Given this list of marker genes ADGRB2, YY1AP1, SKA2, CENPN, MSRB3-AS1, TCTN1, WRAP53, SLC27A1, ZNF57, NDUFS3, BCCIP, FRAT1, UNKL, MTCP1, APOL4, ZC3H7A, BMS1P1, ENSG00000246792, PRELID3BP5, CUL7, SCARB1, PRTFDC1, GLUD1P2, TIGD6, ZNF271P, PODXL (NCBI Gene Id 5420), MAP3K7, MTERF3, PRKAR2A-AS1, FAM131B-AS2, RGCC, MTHFR, RBMXL1, SEPTIN9, TRIM33, LINC01124, VPS37C, KIAA1958, TIMM22 (NCBI Gene Id 95988), KLK8, HCG14, RPS17, NEBL-AS1, SIN3B, KCNAB2, BMS1, QPCTL, MAPKAPK3 (NCBI Gene Id 7867), MROH8, LYST, ATXN2, TOLLIP, TMEM102, C17orf58, CPLX1, WDR82, RNF24, GNAS, DDX56, OS9, SYBU-AS1, TARDBP, MED15, AHI1, KLF6, CMC2, KNL1, DDX5, BCAR3, FAM162A, NUBP2, WDR5-DT, H4C2, ULBP2, H4C12, WDFY3-AS2, MYL12B, TRAPPC9, ZHX1-C8orf76, SUN2, RUNX1T1, MPC1-DT (NCBI Gene Id 119545625), ZNF7, RITA1, PPP1R13L, LINC00896, PSMC3, DPP9, FNTA, NUP58, EHBP1, KYAT3, ASH1L, TMEM191A, SLC17A7, UGT8, FBXO8, CSPP1 (NCBI Gene Id 79848), IER5L-AS1, EVI5, CYP27B1, JMJD1C, RAD51AP1, PAXIP1-DT, HMGB2P1, CCDC157, HES1, SPATS2, SEMA6A, ZCCHC24, AP1G1, ATP8A1-DT, ATG10, MEN1, NFIX, HSDL2-AS1, TCAM1P, PKN1, NRSN2-AS1, LINC01664, CPSF2, EXD1, RPN2, FGF13, ALOXE3, GLUD1P3, NIP7, GTPBP3, TESC-AS1, ZNF300, STARD4, IER3-AS1, PLEKHM3, TMEM64, C2CD2L, ZNF213-AS1, FBXO33, SMIM36, NUP43, PAXIP1, CBX3P4, NOCT, ARHGAP9, FKBP4, CEP44, RPS27A, RIMBP3, COMMD5, FAM193B, COG8, ARL4A, AGRN, CIC, RNF43, MSLNL, NRSN2 (NCBI Gene Id 80023), PNPO, TSEN34, GDF15, MAOA, TMEM191B, ZNRF2, SNX12, SNRPD2, ALAD, MAP1LC3B, MBL1P, HSPE1-MOB4, TMEM260 (NCBI Gene Id 54916), PVALEF, NOX5, RPUSD1 (NCBI Gene Id 64723), MTG2, PDCD10, ATAD2, DVL3, SSX2IP, HNRNPUL1, VTRNA1-2, NT5DC2, CLHC1, ERP29, SPINDOC, ARL1, FOXA1, ANKRD27, PDK3 (NCBI Gene Id 5165), CCDC187, KBTBD8, FLOT1, MED16, BHLHE40, GSK3B, TBC1D5, LINC01287, MED13, ABHD14B, PKIA (cAMP-dependent protein kinase inhibitor alpha), ZSCAN30, MFHAS1, HSPD1, CLSTN1, TOMM20L, C14orf178, ETFDH, NME4, DHCR24-DT, ABR (NCBI Gene Id 82701), BMS1P4, MIX23, TESMIN, UBE2I, CTDSP1, RPS16, DENND2C, PRSS12, NDUFB1, NLGN2, NICN1, STX3, ZSWIM7, PSIP1, AURKA, RPS20P2, ZNF583, TRIP12, NBN (NCBI Gene Id 4683), MIR4449, FERRY3, YBX1, WDR45, KIAA1586, CHTF18, DUSP5, BTF3L4, LINC00115, LINC00540, TDP2, LGR4, ATG13, STPG1, TTLL7, GFOD2, KATNA1, LINC02575, LINC01778, SLC39A8, SLC1A4, SLC7A8, CHP1, ZNF43, CFAP221, NFATC3, TTYH1 (NCBI Gene Id 57348), DPF1, SPSB3, NEK2, GSK3B-DT, CD99L2, MDH1, TESC, MYO10, TXNDC12, CDKL3, UROS, TIGD5, CASP6, NDUFB7, UQCC5, S100A11, OXR1-AS1, TLE3, H4C3, RNASEK, STT3A, RPL23AP53, ATP6V0A2, OGG1, GNG5, WNK4, SKOR2, CHAC1, CELF1, BMAL1, ACTL6B, ADGRG1, C6orf62, RNASEK-C17orf49, RAP2C-AS1, ARF4, THEM6, ZAR1L, ZNF143, EFHB, ENSG00000248161, PRSS16, CEP95, SDHD, SCOC, ART5, STRN, PTPDC1 (NCBI Gene Id 138639), CDCA7L, RAB3IL1, MECOM, CNOT3, MAPRE1, DNAAF5, SPG7, LNCOC1 (NCBI Gene Id 100288181), EMC9, DCAF4 (NCBI Gene Id 26094), FST, SP2-AS1, TCP11L2, ASCC2, LIMD1-AS1, WDPCP, H4C8, STAP2, CTR9, ENSG00000179066, PPDPF, PIK3R3, EBF1, CHD9NB, EEF1D, PRSS23-AS1, DANCR, IST1, ZNF76, ZNF821, BICC1, POLR1G, NUCB1, OXR1, TENT4A, PIAS1, ATP8A1, SLC35E2A, RASGRP4, SMARCE1, H4C11, RAB28, ESCO2, H4C4, BAIAP3, SLC26A4, SNX8, BCL2L11 (NCBI Gene Id 150819), SFSWAP, MIR7-3HG, ZNF143-AS1, TTC19, NHLRC2 (NHL repeat containing 2), TBX1, TMEM121B, DDX54, PCGF3, ANXA6, CDON, PTPMT1, CACNA1A, LINC01128, ZNF792, GALK1, BRSK1, SP5, TSSC4, ATRN (attractin), RAC2, ACP5, RMDN2, ASAH2B, MEMO1, DCBLD2, FAM193B-DT, TST, HDDC2 (HD domain containing 2), MPND, BRCA2, H3C12, LINC00467, MAT2A, MYL12-AS1, IL36RN, SIGIRR, PTDSS1, TRPV2, ZNF548, EIF3B, DNAJB5, ALDH4A1, DGAT2, MIR7-3, TAL1, JRKL-AS1, PAQR4, RRM2, FBXO36, NCOA7, PRIMPOL, RIC8B, NRG2, SETD1A, PEMT, SCN1B, TMEM116, DCLRE1A, MIR1205 (microRNA 1205), TOMM20L-DT, VCF2, WASL, HARBI1, SKIL, CASP3, MBOAT7, CISH, DAP3, DCAKD, FUS, GSTO2, FBXO31, HGH1, PRKCI, PPM1B, ANO8, LCNL1, ZYX, LASP1, FAM131A, MPP7-DT, AAMP, TPRKB, MPST, MTR, SUPT5H (SPT5 homolog, DSIF elongation factor subunit), PKMYT1, DGAT2-DT, GDPGP1, ZNF596, PNPLA3, BMS1P4-AGAP5, DISP3, TIMM17A, SCOC-AS1, RNU6-9, TTLL4, MMP15, NOM1, PIP5KL1, C4orf46, HMGXB3 (HMG-box containing 3), CEP170B, CSTF1, COPS5, SERPINI1, ANKRD13A, GDF11, ELL2, PNKD (NCBI Gene Id 87830), ENOSF1, HSPE1 (NCBI Gene Id 82869), FOS, GMPPB, MCUR1, DHCR24, GSDMA, ATG101, PRR14 (NCBI Gene Id 78994), DIO3OS, PRR11, GYG1, RUNX1, UBE2B, SNORA26, ARFGEF2, GFY, C14orf119, PPP1R3F, H4C5, CRADD, UNC13D, NUCKS1, PRR36, TMEM191C, RGS9BP, SLC2A8, H1-10, ZHX1, NAPRT, DNAJB5-DT, RAB33B-AS1, RAET1L, SPATA24, LDLRAD2, GIPC1, TXNIP, TSNARE1, PPP1R37, BCL6, MCCC2, IMP4, FAUP4, ZNF131, CCDC115 (coiled-coil domain containing 115), GID4, ASB6, PNMT, BRPF1, CES5AP1, C21orf91, KMT2A, SACM1L, here is a description of the gene set: from publication Yevshin I, Sharipov R, Kolmykov S, Kondrakhin Y, Kolpakov F (PMID 30445619) Genes containing one or more binding sites for (ZBTB5) in their promoter regions (TSS -1000,+100 bp) as identified by GTRD version 20.06 ChIP-seq harmonization. studied in species Homo sapiens Human Gene Set: ZBTB5_TARGET_GENES